Given this list of marker genes POLR2I, EEF1E1, HDGF, PSMA2, CTBP1, GNAS, PPP1CA, TUBA1B, PSMB7, RPL14, ATP5MC1, RPS12, UBA1, ANAPC5, RPS10, RPL18, NONO, EIF4H, IST1, EEF1G, COX7C, NIPSNAP1, SEC61B, HPRT1, MRPS12, DOCK3, GANAB, JTB, HSP90AA1, RPS27A, RPL21, COX5B, PRDX1, H2AZ2, RACK1, EIF3H, RPS13, PPP2R1A, PSMB6, PSMD8, PRMT1, CCT3, RHEB, HADHB, VDAC2, LSM2, CNIH1, SMARCD2, RAN, SNRPB2, METAP1, PABPC1, U2AF1 (U2 small nuclear RNA auxiliary factor 1), RBMX, CLTA, TRIM28, DDX39B, ATP5F1C, H2AZ1, UBE2I, ATP5ME, SNRPB, ATP5PF, RPS25, DDX49, KARS1, CDC123, HAX1, EIF3M (NCBI Gene Id 63319), CLNS1A, HINT1, SDHA, IFT25, MYL6B, ERP29, PSMB3, TUFM, SSBP1, HMGN1, TMED2, BCAP31, UQCRFS1, C1QBP (complement C1q binding protein), SUMO3, RAD21, RPL6, RPL11 (NCBI Gene Id 6135), MTDH, EIF4A1, EIF4G2, DNAJC8, ATP6V1F, NME2, COA1, SNRPA, ANP32B, UQCRC2, COX6B1, CS, PHB2, RPL23A, ACLY, YBX1, TPI1, COPE, RUVBL2, YWHAQ, UBE2L3, PPIA, SUMO2, PCNA, YWHAB, PGAM1, COPS5, SRP14, PSMA4, ATP5PO, SRSF3, STARD7, ATXN10, PWP1 (PWP1 homolog, endonuclein), NEDD8, DRG1, SLC25A3, COX7B (NCBI Gene Id 1349), AP2M1, KHDRBS1, UBA2, DYNLL1, EEF1D, TMBIM6, CYC1, COX6C, BUB3, RPL36AL, PRKAR1A, COX7A2L, ATP5MF, TMEM147, MIF, RNPS1, SNRPE, ELOC, CNBP, FDPS, NPM1, DCTN2, SNRPD2, RPLP2, MYL11, TUBB2A, CALM2, PSMB4, UQCRH, PSMC1, RAC1, STOML2, UBB, SLC25A5, PCMT1, ATP5MC3, MRPL23, RPL7, HDAC1, PSMB2, PPM1G (protein phosphatase, Mg2+/Mn2+ dependent 1G), EEF2, RPS6, POLR2H, COPS6, UQCRB, NACA (nascent polypeptide associated complex subunit alpha), ERH, HNRNPAB, FBL, COX8A, CSNK2B, PCBP2, SRSF9, PSMD7, TIAL1, NDUFV1, RPN2, CCT2, PUF60, HNRNPC, MDH1, IDH3B, EBP (NCBI Gene Id 139151), KXD1, PPP1R7, FIBP, SOD1, CYCS, BTF3, PDAP1, LYPLA1, HNRNPA2B1, NME1, XRCC6, SNRPG, EIF3K, NCL, HNRNPA3P1, COX6A1, CANX, SNRNP200, AP2S1, FAU, CCT7, SUMO1 (small ubiquitin like modifier 1), DEK (NCBI Gene Id 7913), EIF3C, EIF1AX, CTDNEP1, SSR2, PDCD6, RPL30, RPS5, SRSF2, YWHAZ, ILF2, HSPD1, TCEA1, NDUFA1, LDHA, RAD23A, NAP1L1, DAP3, BANF1, UTP18, CAPZA1, CBX3, NDUFS3, COMMD4, POLE3, SEM1, RALY, NDUFA2, GPAA1, PTBP1, GATD3, TARDBP, NDUFS5, EIF3E, GPI, MRPL9, PARK7 (NCBI Gene Id 113880), RPS24, FUS, SKP1, HSPA8, SRP9, HNRNPUL1, COX4I1, SET, PGK1, PSMB1, NDUFAB1, COX5A, GDI2, RPL24, XPO1, RPL5, HSP90AB1, ACTG1, HUWE1, RPL13, here is a description of the gene set: Neighborhood of RAN RAN, member RAS oncogene family in the MORF expression compendium Neighborhood of RAN species: Homo sapiens Human Gene Set: MORF_RAN